Given this list of marker genes Man2c1, Man1c1, Man1a (NCBI Gene Id 17155), Man2a2, Man1b1, Man2b1, Maneal, Manea, Man2b2, Man2a1, Man1a2, Manba, Edem2, Edem3, Edem1, here is a description of the gene set: studied in species Mus musculus Mouse Gene Set: GOMF_MANNOSIDASE_ACTIVITY Catalysis of the hydrolysis of mannosyl compounds, substances containing a group derived from a cyclic form of mannose or a mannose derivative.